Given this list of marker genes CCN2, LIFR, COL2A1, KIAA0319L, CDCA7, FGFR2, CCR6, OBSL1, COL11A1, ALG9, ABCC9, CUL7, COL11A2, TMEM53, CAV1, TRIP11, EXTL3, PAM16, IRF5, CCDC8, HSPG2, IFT43, KAT6B, TBX15, HLA-DRB1, INPPL1, here is a description of the gene set: Human Gene Set: HP_ABNORMAL_ISCHIUM_MORPHOLOGY Abnormal ischium morphology An anomaly of the ischium, which forms the lower and back part of the hip bone. species: Homo sapiens